The following is a description of a gene set: Human Gene Set: HP_RAGGED_RED_MUSCLE_FIBERS studied in species Homo sapiens Ragged-red muscle fibers An abnormal appearance of muscle fibers observed on muscle biopsy. Ragged red fibers can be visualized with Gomori trichrome staining as irregular and intensely red subsarcolemmal zones, whereas the normal myofibrils are green. The margins of affect fibers appear red and ragged. The ragged-red is due to the accumulation of abnormal mitochondria below the plasma membrane of the muscle fiber, leading to the appearance of a red rim and speckled sarcoplasm., and this is the list of marker genes: MT-TL1, NEFH, MT-CO3, BCS1L, ALG2, MT-TW (mitochondrially encoded tRNA-Trp (UGA/G)), MT-RNR1, SLC25A42, RRM1, LIG3, NUBPL, SLC25A32, MT-TL2, SLC25A26, PABPN1, MT-TV, YARS2, SLC25A4, MT-TE, MT-TQ, POLG, MT-TK, TK2, PUS1, SDHA, MEGF10 (NCBI Gene Id 84466, multiple EGF like domains 10), MGME1, RNASEH1, EARS2, RRM2B, TWNK, SCN4A, SUCLG1, TRMT10C (NCBI Gene Id 54931), NARS2, SPG7, MT-TS2, MT-ATP6, MT-ATP8, MT-ND6, MT-ND3, TEFM, MYH7, GMPPB, GFPT1, MT-TC, MT-ND4, ALG14, SNUPN, MT-TI, MT-CYB, MT-TF, POLG2, MT-ND2, MIEF2, DPAGT1, MT-CO1, CARS2, MPV17, COQ2, MT-ND1, MT-CO2, TRMU, CHCHD10, AFG3L2, MT-TP, TYMP, MT-TH, MT-TN, DGUOK, MT-ND5, UQCRQ, AIFM1, NDUFS4